Given this list of marker genes Ercc6, Gadd45a, Ifnb1, Ret, Ifng (NCBI Gene Id 15978), Lif, here is a description of the gene set: species: Mus musculus Mouse Gene Set: GOBP_REGULATION_OF_PEPTIDYL_SERINE_PHOSPHORYLATION_OF_STAT_PROTEIN Any process that modulates the frequency, rate or extent of the phosphorylation of a serine residue of a STAT (Signal Transducer and Activator of Transcription) protein.